The following is a description of a gene set: Human Gene Set: GOBP_REGULATION_OF_SYSTEMIC_ARTERIAL_BLOOD_PRESSURE The process that modulates the force with which blood travels through the systemic arterial circulatory system. The process is controlled by a balance of processes that increase pressure and decrease pressure. studied in species Homo sapiens, and this is the list of marker genes: PREP, COMT, TNNI3, ADRB1, ADAMTS16, F2RL1, RASL10B, MAS1, WNK1, SPX, EMP2, EDN2, KLK3, NAV2, NR2F2, CYBA, PDGFB, EDN1, BBS4, AVP, ARHGAP42 (NCBI Gene Id 83935), PCSK5, ADRB2, PTPN1, SOD2, AVPR1B, PTPRO, ADM5, PLCB3, MRGPRD, TACR1, ENG, AVPR1A, CPA3, OXTR (NCBI Gene Id 5021, oxytocin receptor), MANF, MIR17, POSTN, FSHR, CYP4F12, RPS6KA2, AVPR2, EDNRB, CYP4A11, KCNK6, NOX1, CYP4F2, KLK1, SLC4A5, SLC2A5, DDAH1, NMU, CALCA, DRD5, NCALD, APLN, BMPR2, SERPINF2, OR51E2, TTR, GJA5, ASIC2, KL, DRD2, SUCNR1, CMA1, CORIN, ACE, MECP2, AGTR2, GSK3A, HSD11B2, CYP11B2, ADRB3, NTSR1, GPR37L1, KLK2, P2RX2, ECE1, ADRA1A, EDN3, TPM1, ADM, AGTR1, IER3 (immediate early response 3), CRH, CTSG, ENPEP, ADORA1, GAS6, ATP6AP2, NPPB (NCBI Gene Id 4879), ANPEP, NOS3, REN, RARRES2 (retinoic acid receptor responder 2), F2R, ADM2, NPPA (natriuretic peptide A), MME, KCNK3, TNF, PRCP, ACE2, CTSZ, RHOA, CORO2B, AR, NDST2, AGT, TAC1, TAC4